The following is a description of a gene set: The directed movement of a keratinocyte, epidermal cells which synthesize keratin, from one site to another. Human Gene Set: GOBP_KERATINOCYTE_MIGRATION species: Homo sapiens, and this is the list of marker genes: HBEGF, LTB4R2, EPB41L4B, FERMT1, MMP9, ADAM9, KRT2, MTOR, MAP4K4, KRT16 (keratin 16), FGF7, PPARD, FGF10, HAS2, MAPRE2, LRG1, IQSEC1, EPPK1, ARF6, PTEN